Given this list of marker genes Slc35d1, Ugp2, Ugdh, here is a description of the gene set: part of: Glucuronidation species: Mus musculus electronically inferred by orthology from the curated human pathway This event has been computationally inferred from an event that has been demonstrated in another species.<p>The inference is based on the homology mapping from PANTHER. Briefly, reactions for which all involved PhysicalEntities (in input, output and catalyst) have a mapped orthologue/paralogue (for complexes at least 75% of components must have a mapping) are inferred to the other species. Reactome Pathway: Formation of the active cofactor, UDP-glucuronate